The following is a description of a gene set: Reactome Pathway: Transfer of LPS from LBP carrier to CD14 part of: Toll Like Receptor 4 (TLR4) Cascade LBP delivers LPS from bacteria (or bacterial membrane fragments) to CD14 on the surfaces of phagocytes, where it is recognised by the MD2:TLR4 complex. Thus, LBP is an opsonin and CD14 is an opsonic receptor for complexes of LPS (or LPS-containing particles such as bacteria) and LBP. CD14 exists as two isoforms. CD14 can be either secreted into the extracellular compartment, or it can be anchored to the plasma membrane via its GPI module. studied in species Homo sapiens, and this is the list of marker genes: CD14, LBP (lipopolysaccharide binding protein)